The following is a description of a gene set: Mouse Gene Set: CUI_MIGDC_OSM_RESPONSE_UP Cytokines mediate cell-cell communication in the immune system and represent important therapeutic targets. A myriad of studies have highlighted their central role in immune function, yet we lack a global view of the cellular responses of each immune cell type to each cytokine. To address this gap, the authors created the Immune Dictionary, a compendium of single-cell transcriptomic profiles of more than 17 immune cell types in response to each of 86 cytokines (>1,400 cytokine-cell type combinations) in mouse lymph nodes in vivo. A cytokine-centric view of the dictionary revealed that most cytokines induce highly cell-type-specific responses. For example, the inflammatory cytokine interleukin-1β induces distinct gene programmes in almost every cell type. A cell-type-centric view of the dictionary identified more than 66 cytokine-driven cellular polarization states across immune cell types, including previously uncharacterized states such as an interleukin-18-induced polyfunctional natural killer cell state. Genes positively differentially expressed in cell type: MigDC (migratory dendritic cell) upon treatment with cytokine: OSM in mouse lymph nodes in vivo. studied in species Mus musculus from publication Cui A, Huang T, Li S, Ma A, Pérez JL, Sander C, Keskin DB, Wu CJ, Fraenkel E, Hacohen N (PMID 38057668), and this is the list of marker genes: Fam53b, Pdcd4 (programmed cell death 4), Arpc1b, Serpina3g, Slc27a3, Tsc22d3, Ppp1r12a, Npr1, Il7r, Ifitm2, Slfn2, Runx1, Tspo, Psmc3, Filip1l, Rnaset2a, Actr3